Given this list of marker genes Wapl (NCBI Gene Id 320218), Faxc, Cdr2, Chchd3, Tia1, Nfatc1, Wwp1, Rasgrp2, Mapk10, Pan2, Bank1, Itsn1, Strip2, Ercc6, Pag1, Zfp114, Marchf2, Ephb3, Tmprss11f, Eomes, Senp2, Abcc3, Rgs3, Frem2, Usp54, Brpf3, Adgrl3, Bpnt2, Fhip1a, Mgll, Rhobtb3, Dync2i1, Kpna6, Pigk, Ccdc7a, Cs, Stk26, Sec16b, Cnbp, Ndc1, Akr1c14, Prpf39, Ncf2, Stat5a, Rhoa, Rab2a, Nr3c2, Mob3c, Dclk1, Zic3, Cp, Hyal4, Champ1, Npr2, Fam193a, Rad23a, Plekhf2, S100a5, Frmd6, Lrrc39, here is a description of the gene set: from publication Chen Y, Wang X (PMID 31504780) Mouse Gene Set: MIR_8092 Genes predicted to be targets of miRBase v22 microRNA mmu_miR_8092 in miRDB v6.0 with MirTarget v4 prediction scores > 80 (high confidence targets). studied in species Mus musculus